The following is a description of a gene set: studied in species Homo sapiens Human Gene Set: GOMF_BETA_N_ACETYLHEXOSAMINIDASE_ACTIVITY Catalysis of the hydrolysis of terminal non-reducing N-acetyl-D-hexosamine residues in N-acetyl-beta-D-hexosaminides., and this is the list of marker genes: OGA, HEXA, HEXB, GM2A, HEXD